The following is a description of a gene set: studied in species Mus musculus Mouse Gene Set: CUI_MACROPHAGE_IL1A_RESPONSE_UP Genes positively differentially expressed in cell type: Macrophage upon treatment with cytokine: IL-1α in mouse lymph nodes in vivo. from publication Cui A, Huang T, Li S, Ma A, Pérez JL, Sander C, Keskin DB, Wu CJ, Fraenkel E, Hacohen N (PMID 38057668) Cytokines mediate cell-cell communication in the immune system and represent important therapeutic targets. A myriad of studies have highlighted their central role in immune function, yet we lack a global view of the cellular responses of each immune cell type to each cytokine. To address this gap, the authors created the Immune Dictionary, a compendium of single-cell transcriptomic profiles of more than 17 immune cell types in response to each of 86 cytokines (>1,400 cytokine-cell type combinations) in mouse lymph nodes in vivo. A cytokine-centric view of the dictionary revealed that most cytokines induce highly cell-type-specific responses. For example, the inflammatory cytokine interleukin-1β induces distinct gene programmes in almost every cell type. A cell-type-centric view of the dictionary identified more than 66 cytokine-driven cellular polarization states across immune cell types, including previously uncharacterized states such as an interleukin-18-induced polyfunctional natural killer cell state., and this is the list of marker genes: Cd274, Hsbp1, Hmox1, Nup153, Snx8 (sorting nexin 8), Tuba1c, Rab20, Ranbp2, Eif4e, Eif4a1, Ddb1, Spred1, Daxx, Plaur, Ranbp1, Snu13, Ccl2, Fyn, Ccl7, Glipr2, Slfn2 (schlafen 2), Nolc1, Ybx3, Rab3il1, Cdk2ap2, Bcl2l1, Serbp1, Ctnnd1, Pim1, Nsun2, Dok2, Tes, Runx1, Sdc4, Tma16, Msr1, Fth1, Hs3st3b1, Larp1, Bcl2a1d, Rsl24d1, Serpina3g (NCBI Gene Id 20715), Lpar1, Plek (NCBI Gene Id 69998), Ifrd1, Anp32e, Wnk1, Trim30a, Set, AA467197, Bhlhe40, Tfec, Cebpd, Ddx21, Bcl2a1b, Palld, Ms4a6d (membrane-spanning 4-domains, subfamily A, member 6D), Ccl6, Eif5a, Fkbp5, Riok3, C5ar1, Ccl12, Noc3l, Myd88, Dthd1, Ifi204, Actg1, Vapa, Cd209e, Fcgr3, Lilrb4b (leukocyte immunoglobulin-like receptor, subfamily B, member 4B), Impdh2, Tomm20, Picalm, Lrrc59, Plin2, Odc1, Susd6, Dkc1, Pnp, Ran, Stat3, Cnbp, Tgm2, Eef1e1, Ncl, Clic4, Etf1, BC005537, Mt2, Btg1, Ifi207, Basp1, Enah, Il4ra, Rrp15, Steap4, Fabp5, Litaf, Eif4g2, Lgmn, Nlrp3, Rbms1, Fcgr2b (NCBI Gene Id 98391), Ptbp3, Dab2, Socs3, Wfdc17, Ms4a4c, Myl12a, Slfn8, Ccl9, Cdv3, Tubb6, Uck2, Scimp, Srm, Ilrun, Socs2, Wdr12, Hbegf (heparin-binding EGF-like growth factor), Eif2ak2, Prkcd, Eif1, Srgn, Psme3, Kdm6b, Ccl17, Il1b, Gbp7, St3gal4, Ptpn1, Ctu2 (NCBI Gene Id 66965), Cd14, Eif1a, Eef1g, Gpt2, Txnrd1, Clec4n, Casp8, Agfg1, Gar1, Ppp2ca, Eif2s2 (NCBI Gene Id 99435), Arid5a, Xbp1, Eps8, Rara, Il1rn, Bzw1, Junb, Bzw2, Ywhag (NCBI Gene Id 52802), Glrx, Evl, Atp6v1b2, Bach1, Jaml, Mafb, Stk40, Ywhaz, Csrp1, Il1a, Rap2a, Ppan, Rin2, Rab14, Llph, Gk, Mt1, Id2, Nopchap1, Scamp1, Mybbp1a, Sec23ip, Dnajc21